The following is a description of a gene set: species: Homo sapiens Human Gene Set: WP_MAPK_SIGNALING_AND_ARTD_FAMILY_MEMBERS MAPK signaling and ARTD family members, and this is the list of marker genes: BRAF, DUSP1, MAP2K3, MAPK11, MAP3K5, MAP3K10, MAP3K1, MAP3K8, MAPK9, MAPK8, TNKS, MAP3K9, ATF4, MAP3K7, PARP14, MAPK3, MAPK10, MAPK13, MAP2K7, MAPK1, MAP3K21, ARAF, MAP2K4, MAPK12, MAP2K1, PARP1, MAP3K11, MAP2K2, MAP3K12, RAF1, MAP2K6, MAPK14